Given this list of marker genes ATG13, ATG16L1, VPS16, UBQLN1, UBQLN4, C9orf72, TBC1D14, PIK3R4, TBC1D17, GABARAPL1, TBC1D25, PIP4K2B, ATG5, WASH3P, GRAMD1A, CLN3, TM9SF1, OPTN, CHMP4BP1, CHMP7, CALCOCO2, TMEM150B, GABARAPL3, AMBRA1, TICAM1, CHMP6, RAB30, CHMP4A, UVRAG, ULK2, TBC1D5, RAB12 (NCBI Gene Id 201475), NBR1, RUFY4, BECN1, ENTPD4, LAMP1, WDR81, IRGQ, FTL, CHMP4B, CHMP4C, ATP13A2, WASHC1 (NCBI Gene Id 727741), TECPR1, TP53INP1, TP53INP2, CHMP2A, ATG12 (NCBI Gene Id 9140), PIK3C3, ULK3, ATG14, AUP1, MYO6, VTI1A, DAPK2, PEG3 (NCBI Gene Id 5178), PRKD1, ATG9A, GABARAP, MEFV, FTH1, VMP1, RB1CC1, ATG16L2, CHMP1A, HTT, CHMP5, UBQLN2, TMEM74, SQSTM1, ZFYVE1, CHMP2B, NRBF2, STX17, CHMP3, TEX264, RUBCNL, ULK1, VPS11, GABARAPL2, CHMP1B, MAP1LC3B2, RAB23, PIP4K2C, WIPI2, RAB7A, STING1, OSBPL7, RAB2A, TMEM230, LRRK2, MAPK15, HAP1, IRGM, SH3GLB1, WIPI1, VPS33A, WDFY3, NCOA4, TAX1BP1, JMY, LAMP2, MCOLN3, VPS18, ATP6AP2, TRIM21, MAP1LC3A, RAB3GAP2, ATG4B, ATG9B (NCBI Gene Id 442783), FYCO1, MAP1LC3B, TRIM32, TBC1D12, SNAP29, RAB2B, RAB24, PIP4K2A (NCBI Gene Id 5305), SRPX, MAP1LC3C, here is a description of the gene set: Human Gene Set: GOCC_AUTOPHAGOSOME species: Homo sapiens A double-membrane-bounded compartment that engulfs endogenous cellular material as well as invading microorganisms to target them to the lytic vacuole/lysosome for degradation as part of macroautophagy.